The following is a description of a gene set: Binding to a disordered domain of a protein. Mouse Gene Set: GOMF_DISORDERED_DOMAIN_SPECIFIC_BINDING species: Mus musculus, and this is the list of marker genes: Cltc, Ezr, Trp53, Gja1, Siah1a, Gja5, Myo5a, Mdm2, Gapdhrt2, Smad2, Rb1, Ppil1, Dffb, Kcna1, Numa1, Gapdh, Tpm1, Smtnl1, Hsp90ab1, Fyn (Fyn proto-oncogene), Hspa1a, Hspa2, Fkbp8, Bcl2l2, Rrm1, Crebbp, Cdkn2a, Gapdh-ps15, Ap2a2, Tead2, Ap2m1, Ncoa3, Keap1 (NCBI Gene Id 54157), Hsp90aa1, Gapdhrt, Ctnnb1